The following is a description of a gene set: species: Homo sapiens Genes up-regulated in fibroblasts expressing the XP/CS mutant form of ERCC3, after low dose UVC irradiation. Human Gene Set: DACOSTA_LOW_DOSE_UV_RESPONSE_VIA_ERCC3_XPCS_UP Xeroderma pigmentosum (XP) and trichothiodystrophy (TTD) syndromes are characterized by deficiency in nucleotide excision repair pathway, but with distinguished clinical manifestations. While XP patients exhibit a high frequency of skin cancer, TTD patients are not cancer prone. The relation between lack of DNA repair and their clinical manifestations was investigated through analysis of the transcriptional profile of 12,600 transcripts in two isogenic cell lines with different capabilities of DNA repair. These cell lines result from a stable transfection of the XPB-TTD allele into XP complementation group B fibroblasts, from an XP patient who also have clinical abnormalities corresponding to Cockayne's syndrome (CS). The microarray assays performed under normal growth conditions showed the expression of distinct groups of genes in each cell line. The UVC-transcription modulation of these cells revealed the changes in 869 transcripts. Some of these transcripts had similar modulation pattern in both cells, although with eventually different time patterns for induction or repression. However, some different 'UVC signature' for each cell line was also found, that is, transcripts that were specifically UV regulated depending on the DNA repair status of the cell. These results provide a detailed portrait of expression profiles that may potentially unravel the causes of the different phenotypes of XP/CS and TTD patients. from publication da Costa RM, Riou L, Paquola A, Menck CF, Sarasin A (PMID 15608684), and this is the list of marker genes: POU2F3, ITPKA, PRDM2 (PR/SET domain 2), H2AC18, PINK1, FXYD2, ELF1, SHROOM2, FAS, USH2A, PTPN22, H1-5, MUSK, TK2